Given this list of marker genes PPP1R17, MAP4K2, HSPA1A, NPRL2, EVI5, PAQR3, ECM1, PILRB, NT5DC2, TOM1L1, ASAP3, PDCD4, PTPN22 (NCBI Gene Id 5779), MAP2K1, SPOCK2, STX4 (syntaxin 4), FGD2, SEMG2, SERPINB4, NOSIP, MAPK8, ARFGEF1, DUSP1, BLM, APBA3, PRDX3, DBNDD2, ADARB1, PTPRJ (NCBI Gene Id 5795), RGS16, HNRNPU, CAMKK2, GUCA1ANB-GUCA1A, FETUB, MIR138-1, FGF18, ADAM17, CARD14, IGF1, ADORA2B, CDKN3, ESR1, PARP9 (NCBI Gene Id 83666), CDC20, STRADA, SOCS5, PRKG1 (protein kinase cGMP-dependent 1), DOCK10, STK11, PLXNB2, PKMYT1, CACUL1, AKT1S1 (NCBI Gene Id 84335, AKT1 substrate 1), SYAP1, RAP1GAP, CORO1C, TRIB1, PLK1, TSPYL2, ETAA1, CENPE, RIC1, TBC1D2, S100A12, KLRC4-KLRK1, TSC1, BANF1, MAPK8IP1, ABL1, RALGAPB, RAP1A, CDK12, CHTF8, MAP3K7 (NCBI Gene Id 6885), TRIB2, P2RY11, RAPGEF3, USP6NL, NTRK2, POLG2, PSMD10, GADD45A, BCAR3, INS, NRG1, ELANE, PSAP, ACP4, BVES, BMP2, KSR1, TIGAR, TRAF2, PDE3A, PIBF1, TBC1D20, BMI1, HGS, TNFSF15, NHEJ1, GPSM1, ECSIT, MTSS2, XRCC4, SNX6, PTPN1, SERPINB1, MMUT, URI1, ARHGEF16, RPS2, GZMA, PLAAT4, CHP2, NEDD9, CEP85, CDKN1B, USP17L2, AVPR2, DIRAS2, SYDE2, XRCC1, CCNK, FLT3, DAB2IP, SNCA, APC, HIPK3, TRIM27, ANGPT1, MMD2, CD300A (NCBI Gene Id 11314), DSCC1, ADGRV1, FGD5, COX17, VCP, MAGEA2, DIPK2A, PRELID1, GUCA1A, TIAM1, CCDC125, AKT1, CD4, RALGAPA2, ODAM, GPRC5A, EPHA4, FGFR2, RCC2, PIH1D1, GPLD1 (NCBI Gene Id 2822), ZC3H15, CARD10, GRM2, SIRT4, RBL2, USP44, PHACTR4, ERBB2, UNC119, LARS1, TBC1D10B, PRLR, TIMP1, HPF1, ITGA6, FXN, PRKN, BCCIP, ARHGEF5, RB1, MT3, PTK6 (NCBI Gene Id 5753), SOD1, DOCK11, XRCC6, PTK2, RFC3 (NCBI Gene Id 5983), ADAR, MAD2L2, PCNA, RFC5, PIP5K1A, ATP13A2, UBE2C, TANK, CHTOP, TLR3, PDCD10, TFAP4, RBL1, GTF2H1, EREG, PRTN3, RAPGEF2, RASA4, LDB1, INCA1, CHP1, CACNA1D, SPOCK3, TRIB3, B3GAT3 (beta-1,3-glucuronyltransferase 3), ADCYAP1, CAPN1 (calpain 1), ARAP1, STMN1, TENM1, GABBR2, ERN1 (NCBI Gene Id 63433), GNAI3 (NCBI Gene Id 2773), CAMK1, STOX1, PPM1E, RPS3, CDH3, CRK (CRK proto-oncogene, adaptor protein), GLP1R, SIPA1L1, MTMR9, CCNT2, EFNA5, RRP1B, KLRK1, CR1, FGF16, CD74, LATS1, APOE, NET1 (neuroepithelial cell transforming 1), EPHA5, ZFYVE28 (zinc finger FYVE-type containing 28), UVRAG, CDC25C, NES, VAV2, LDB2, GNAT1 (G protein subunit alpha transducin 1), SCRIB (NCBI Gene Id 23513), FGFR1, TMED2, RFC2, CEP43, CREB3, CDK5R2, PAK2, CIB1, FGD4, SERPINB3, PDGFRB, DFFA, MACROH2A1, MVP, DIRAS1, DSTYK, RAPGEF1, BCAS3 (NCBI Gene Id 89751), SERTAD1, DBI, BAG5, RAP2B, RGS8, SPDYA (NCBI Gene Id 245711), GPRC5B, CAB39, SRCIN1, APC2, COPS8, DOCK8, SYDE1, ECT2, CCNY, KIF14, GCKR, LIMS1, STRADB, SYNPO2, ADORA3, GIPR, CDKN1A, STIM1, BCR, AGRN (NCBI Gene Id 389836), EMP2, ORAI1, RANGAP1, ATP5IF1, VPS25, DOCK9, LTF, JAK2, RIPOR2, LYN, HERC5, FICD, RECK, CDK5R1, MAP2K2, NF1, AGT, RACK1, MAP3K10, CHTF18, TNF, PKIA, ADAP1, EPHB3, CRIPTO, MARCHF6-DT, SERPINA5, PRDX5 (peroxiredoxin 5), SETMAR, ZFP36 (ZFP36 ring finger protein), DEPTOR, FLT1, SRGAP2, MST1, DEFB114, DOK7, ERRFI1, RAB11FIP2, LCP2, GALR1, ARRDC3, TAOK3, NPM1, JMJD8, PDGFB, HLA-DRB1 (NCBI Gene Id 730415), LRCH1, FGR, SH3BP4, NEK10, DIRAS3, TPD52L1, TRAF4, CHI3L1, MAP3K4, TIMP2, RALBP1, RSU1, ABR, NHERF1, WRN, CDC25A, VAV3, CCNG1, PSENEN, CRB2 (NCBI Gene Id 286204), FGF23, ADCY8, NGEF, SPHK2, IFNG, PTK2B, EPHA2, YWHAG, LMO4, STK38, DYNAP, NDEL1, ARHGAP11B, PLA2G5, TNFRSF10A, MIDN, TBC1D7, SNX9, PPP1R12A, CSF1R, SERPINB13, ZGPAT, WNT5A, RALGAPA1, LAT, PROM2, EPHA3, CDC37, RAP2C, RAPGEF6, MAGEA2B, AZIN2, RIPK3, MIA2, AIDA, SNX18, CDC6, GAS6, RPL11, ABCE1, MAPK3, HMGA2, RPS7, LILRA5, TNFRSF10B, TSG101, PLSCR1, NPR3, CCNE2, FGD1, PIM1, PLXNB1, TAB2, BTRC, CHMP6, SERPINB8, CEACAM1, RASGRP1, PYCARD, TCIM, FGFR3, DTX3L, UBXN1, OAS3, RCN3, RTN4R, GNAS, PRKCD, SZT2, DVL3, MAGEC2, LATS2, CDKN1C, TRAF6, RIPOR1, ARHGEF7 (Rho guanine nucleotide exchange factor 7), GPR137B, PLIN5, TMIGD3, PHB2, EPM2A, DDR2, SGSM2, SFN (stratifin), SGK1, PIK3CG, VAV1 (vav guanine nucleotide exchange factor 1), CDK5RAP3, RABGAP1, RGS1 (NCBI Gene Id 5996), IL1B, ARL2, GNAI2, F2RL1 (NCBI Gene Id 7901), IRGM, OAS1, OXA1L, ARHGAP44, PUM3, PPP1R3F, LRRK2, CRHR1, ZNF16, FZR1, CEMIP, RHOG, RGS7, RPL23, DRD5 (dopamine receptor D5), RGP1, GSK3A, ADIPOQ, ANKLE2, SIRT1, FIRRM, RFC4, RASIP1, TMSB4X, EEF1A2, FGF1, PLXNB3, RFK, SNF8, FGF2, CAND1, CALCA, RHOC, NTRK1, CCR2, ALS2, SMG8, TBC1D15, TPX2 (NCBI Gene Id 23477), MID1IP1, WARS1, GNB5, PPIA, SEMG1, EIF4A2, CLSPN, ITGB1BP1 (integrin subunit beta 1 binding protein 1), TBC1D30, MRNIP, CAP2, AGAP2, SKP1, PRKCH, ABI1, SERPINB9, ACR, FBN1, TARBP2, GCH1, RPL5, FGD3, RGS14, GRM3, PTPRC, MAPK14, PABPN1, MBP, MEN1, MST1R, TGM2, THY1, GSKIP, SGSM3, GLA, EVI5L, MET, FEM1B, MAP3K5, S100A10, EDNRA (endothelin receptor type A), FGD6, GAPDH, RHOA, ZFP91, TMBIM1, RTRAF, CDK5RAP1, PIK3R6, MAP2K3, PRSS22, TAF7, SNX13, FEM1A, CDKN2A, CCAR2, CAP1, RGS6, HEG1, EDN2, A2ML1, GSK3B, RDX, RAB3GAP2, NEIL1, DNAJA1, SRC, MMD, MAP3K11, EZH2, LEP, DUSP7, RGS10, CIMAP3, SPINDOC, NPPA, NLRC5, ITGB1, ZNF622, RAB3GAP1, RASSF2, MYCNOS, SH3BP1, CAMK2A, GBA3, XRCC5, RLN2, SEMA4D, SASH1, HMGB1, JTB, FBXO5, FGFR4, EDNRB, TP53, SOCS4, MAD2L1, PIK3R5, SSBP1, LTB4R2, CCNT1, CASS4 (Cas scaffold protein family member 4), UBE2S, EPPIN, GRN, AKAP5, RD3, CCDC88A, SIRT3, PNLIP, ARHGAP11A, CDC14B, ARHGAP42, TLR6 (toll like receptor 6), ATPSCKMT, RASGRP2, EDN1, NOTCH1, SVBP, ARRDC4, DRD4, CACNA1C, VSIR, RALB (RAS like proto-oncogene B), here is a description of the gene set: species: Homo sapiens Any process that modulates the activity of an enzyme. Human Gene Set: GOBP_REGULATION_OF_CATALYTIC_ACTIVITY